The following is a description of a gene set: species: Homo sapiens Human Gene Set: HP_HEMOPHAGOCYTOSIS Phagocytosis by macrophages of erythrocytes, leukocytes, platelets, and their precursors in bone marrow and other tissues. Hemophagocytosis, and this is the list of marker genes: ZNFX1, XIAP (X-linked inhibitor of apoptosis), ITK, LYST, STXBP2, MPL, DNASE2, IFNG, TLR8, JAK2, CALR, HAVCR2, CD27, SH2B3, PRF1, CBLB, PIK3CG (phosphatidylinositol-4,5-bisphosphate 3-kinase catalytic subunit gamma), SLC7A7, STX11, RAB27A, SH2D1A, UNC13D